The following is a description of a gene set: studied in species Homo sapiens An abnormal increased concentration of parathyroid hormone. Elevated circulating parathyroid hormone level Human Gene Set: HP_ELEVATED_CIRCULATING_PARATHYROID_HORMONE_LEVEL, and this is the list of marker genes: CYP3A4, CYP27B1, STX16, NF1, CDKN1B, PHEX, MEN1, GNAS, MIR140, CMPK2, CDC73, CYP2R1, SLC34A1, CLDN16, PDE4D, GCM2, GNAS-AS1, PRKAR1A, SOST, CASR, KL, UMOD, SEC61A1, VDR